The following is a description of a gene set: species: Homo sapiens Human Gene Set: HP_WIDE_NASAL_RIDGE Wide nasal ridge Increased width of the nasal ridge., and this is the list of marker genes: TBL1XR1, METTL5, FOXP2, AP4M1, SUZ12, ALX4 (ALX homeobox 4), POLR3A, HNRNPK, MSL3, RPL10